The following is a description of a gene set: Human Gene Set: GOMF_INTEGRIN_BINDING Binding to an integrin. species: Homo sapiens, and this is the list of marker genes: ADAM11, HSPG2, ITGA8, NRG1, ESM1 (endothelial cell specific molecule 1), CCN2, TNN, FERMT1, CCN1, NF2, CD177, LAMA5, S1PR2, VWF, LYN, CD81, ITGA3, SEMA7A, FBLN1, FGF2, FN1, PRKCA, ADAMTS5, TLN2, APP, COMP, DMP1, CDH26, CDH17, DST, CXCL12, F11R, ITGAE, CCN6, ITGB3, LRP12, JAM3 (junctional adhesion molecule 3), CD9, ACTN3, FCER2, ADAM15, CD40LG, NPNT, LAMB1, ITGB5, ITGAV, ITGA4, ADAM9, ITGB1, IGF2, CASR, MYH9, ADAM2, LCP1, COL3A1, SYK, VCAM1, ANXA7, ECM2, GFAP, UTRN, CD151, LAMB2, JAML, ITGA2B, ITGA1, ITGA6, CCN3, GFRA1, TNC, P4HB, ACTN1, ADAM17, EGFL6, ILK, THY1, FAP, ITGAD, ADAM10, ITGB1BP2, ICAM4 (NCBI Gene Id 3386), ITGA2, PTK2, ITGAM, SELP, S1PR3, SPP1, VTN, ITGB7, ITGB4, CCN5, GPNMB, CCN4, EMP2, CALR, LGALS8, IBSP, ITGAL, ITGB6, THBS4, ITGA11, FBLN5, THBS1, TLN1, SVEP1, ICAM5, FERMT3, IL1B, ITGA10, LTBP4, ITGA5, KDR, ITGA7 (NCBI Gene Id 81988), TGFBI, ITGB8, FERMT2, ICAM3, ITGAX, ANGPTL3, PTPN2, PPIA, COL4A3, EDIL3, PLPP3, FBN1, COL16A1, HMGB1, ITGB1BP1, ICAM1, ADAMTS8, SFRP2, TSPAN8, SRC, IGF1 (insulin like growth factor 1), JAM2, ADAM22, EMILIN1, ITGA9, ICAM2, ISG15, ITGBL1, CD226, ACTN4, TNXB, FRMD5, TSPAN4, ADAM23, CX3CL1, PTN, MADCAM1, FGF1, MMP14, NISCH, SLC6A4 (solute carrier family 6 member 4), COL5A1, ACTN2, CXADR, ITGB2, ADAMTS13, MFGE8, CIB2, PTPRZ1